The following is a description of a gene set: Mouse Gene Set: GOBP_INORGANIC_ION_IMPORT_ACROSS_PLASMA_MEMBRANE studied in species Mus musculus The directed movement of inorganic ions from outside of a cell, across the plasma membrane and into the cytosol., and this is the list of marker genes: Kcnj2, Scnn1b, Akap5, Slc39a8, Kcnk9, Slc12a3, Kcnh2, Scn5a, Slc12a1 (NCBI Gene Id 99066), Abcc9, Kcnk5, Slc5a1, Kcnj6, Pawr, Kcnj13, Adrb2, Slc39a11, Kcnj11, Trpv6, Slc39a6, Slc39a4, Slc39a12, P2rx1, Atp1a1, Atp4a, Slc30a5, Ppp3r1, Kcnj9, Ppp3cc, Steap2, Ms4a1, Slc39a10, Atp4b, Cacna1f, Kcnj3, Atp1b1, Kcnj5, Nalf1, Slc9c1, Dlg1, Ppp3ca, Scnn1g, Kcnj1, Wnk1, Trpm1, Ppp3r2 (NCBI Gene Id 230166), Slc6a1, Grm6, Slc9a3, Slc8a1, Slc9a9 (solute carrier family 9 (sodium/hydrogen exchanger), member 9), Slc9a7, Slc5a2, Slc24a2, Kcnd3, Cacna1d, Slc12a2, Slc5a6, Atp1a2, Kcnj8, Slc12a8, Trpm2, Slc9a2, Slc34a1, Slc12a4, Aqp8, Slc12a5, Lcn2, Cacna1b, Cav1, Kcnj14, Fyn, Cacna1s, Trpm4, Kcnj10, Slc8a3, Atp1a4, Slc11a2, Trpv1, Kcnj15, Cacna1e, Hcn2, Kcne2, Slc9a4, Slc30a8, Nalf2, P2rx5, Slc9a1, Slc24a4, Trpv2, Ppp3cb, Slc9a6, Kcnj12, Trpv5, Slc30a1, Atp12a, Slc12a6, Ifng, Atp1a3, Kcnj4, Atp1b3, Ank3, Slc39a14, Trpv3, Atp1b2, Prnp, Slc9a5, Kcnn4, Slc12a7, Cnga3, Wnk4, Slc39a5, Kcnq1, Fxyd2, Trpv4 (transient receptor potential cation channel, subfamily V, member 4), Wnk2, Kcnj16, Slc8a2, Slc31a1, Scnn1a, Cacna1c, Wnk3, Asic5, Agtr1a, Hcn4, Iscu, Cacna1a, Adrb1